The following is a description of a gene set: Mouse Gene Set: GOBP_BASE_CONVERSION_OR_SUBSTITUTION_EDITING Any base modification or substitution events that result in alterations in the coding potential or structural properties of RNAs as a result of changes in the base-pairing properties of the modified ribonucleoside(s). species: Mus musculus, and this is the list of marker genes: Apobec2, A1cf, Aicda, Adat2, Adad2 (adenosine deaminase domain containing 2), Apobec1, Adarb2, Adar, Rbm47, Adad1, Apobec3 (apolipoprotein B mRNA editing enzyme, catalytic polypeptide 3), Adarb1